Given this list of marker genes CPLANE1, OFD1, DDX59, C2CD3, IFT57, PRKACA, CD96, DYNC2LI1 (NCBI Gene Id 51626), NEK1, SCNM1, FLNA, TELO2, KIAA0586, PRKACB, EFTUD2, IFT140, TCTN3, GLI3, CHUK, here is a description of the gene set: Extra fold of tissue extending from the alveolar ridge to the inner surface of the upper or lower lip. Accessory oral frenulum studied in species Homo sapiens Human Gene Set: HP_ACCESSORY_ORAL_FRENULUM